The following is a description of a gene set: studied in species Mus musculus Mouse Gene Set: GOMF_TRANSMEMBRANE_RECEPTOR_PROTEIN_PHOSPHATASE_ACTIVITY Combining with a signal and transmitting the signal from one side of the membrane to the other to initiate a change in cell activity by catalysis of the reaction: a phosphoprotein + H2O = a protein + phosphate., and this is the list of marker genes: Ptpn6, Ptprf, Ptprc, Ptprt, Ptprm